The following is a description of a gene set: from publication Chen Y, Wang X (PMID 31504780) Genes predicted to be targets of miRBase v22 microRNA hsa-miR-7150 in miRDB v6.0 with MirTarget v4 prediction scores > 80 (high confidence targets). species: Homo sapiens Human Gene Set: MIR7150, and this is the list of marker genes: CYP26B1, SMPD3, PACS2, TPI1, TCF19, SCUBE3, DOLPP1, SNAI2, MARCHF3, GPR22, EIF2B1, ZDHHC8 (zinc finger DHHC-type palmitoyltransferase 8), RND2, UBE2N, NCKAP1, SSH2, ATG9A, PRKD3, STAG1, MEF2C (NCBI Gene Id 4208), RPS9, RAD51D, ADAM19, VSNL1, AKT1S1, SAP30L, UBE2W, KCNH1, CDH10, FOXN3, CTDSPL, ZNF689, ZFP41, TAPT1, SINHCAF, FOXP2, PPP2R3A, C17orf107, GPSM1, CACNB4, LTBP2, NOS1, POP1, JPH2, MMD, PLCB3, CFL1, MYO5C, TICAM2, SLC25A26, DDX3X, TBL1XR1, CERS2, SOSTDC1, POFUT1, IL21R, VANGL2, PEG10 (paternally expressed 10), CCSER2, SLC39A1 (NCBI Gene Id 96436), FOXN2, NAV1, CABLES2, STMN1, GABRB1, AKAP1 (NCBI Gene Id 8165), ZFR, SYPL2, AIP, PHIP, FAM167A, SCN2B, RNF13 (NCBI Gene Id 11342), ZNF555, ETV5, HAS2, HABP4, ADGRA2, RARG, BAZ2A, AZI2, BICD2, PDE3A, PEF1, KDM6A, MORN4, PML, APCDD1, FYCO1 (NCBI Gene Id 79687), TOPORS, F13A1, PPP1R12A, TRIO, B3GNT2, TSNARE1, PAIP1, CASP10, HBEGF, RNF217 (ring finger protein 217), RGS9BP, AMOTL2 (NCBI Gene Id 51421), ZHX3, CACNA2D1, SEPTIN6, ONECUT2, NSG2, PDE4B, TTBK2, TAF4B, RAB9B, PLP2, RAPGEF6, HCN3, FABP3, RABGAP1, GBP3, PHB1, PFKFB2, ABLIM2, MEDAG, EDAR, MGMT, MAP1B, KCNH5, ELAVL4, KRT19, IL5RA, HOOK3, FRMD4A, NR6A1, LPCAT3, PGLYRP4